The following is a description of a gene set: Any biological process involved in the maintenance of the steady-state number of hematopoietic stem cells within a population of cells. Human Gene Set: GOBP_HEMATOPOIETIC_STEM_CELL_HOMEOSTASIS studied in species Homo sapiens, and this is the list of marker genes: ADGRG1, ARMCX5-GPRASP2, ZNF251, ADAR (adenosine deaminase RNA specific), SEPTIN4, SOX4, MTCH2, OCIAD2, FBXO21, EMCN, CRISPLD1, UBAP2L, CADPS2, BAP1, GPRASP2, GATA2, ZNHIT1, FOXA3, NLE1, FSTL1, EXT1, P2RY14, TCIRG1, ARHGEF5, MYCT1, OCIAD1, CCN3, GLIS2, ARMCX1